The following is a description of a gene set: Mouse Gene Set: GOBP_MUSCLE_CELL_CELLULAR_HOMEOSTASIS The cellular homeostatic process that preserves a muscle cell in a stable functional or structural state. studied in species Mus musculus, and this is the list of marker genes: Csrp3, Cfl2, Ank, Pln, Sod1, Gaa, Aldoa, Pfkm, Plg, Il6, Prkca, Lox, Fxn, Chrna1, Apc, Trim32, Mstn, Enpp1 (ectonucleotide pyrophosphatase/phosphodiesterase 1), Bag3, Hif1a, Cav1, Mtm1, Srf, Lamp2, Large1, Tgfb1, Dmd